Given this list of marker genes LHX5, LHX1, ASCL1, LMO4, TAL1, PAX7, GSX2, DRGX, GDF7, LHX3, GDNF, WNT1, PROX1, DRAXIN, PBX3, WNT3A, GSX1, DAAM2, MDGA1 (NCBI Gene Id 57164), HOXB8, UNCX, here is a description of the gene set: The process whose specific outcome is the progression of the dorsal region of the spinal cord over time, from its formation to the mature structure. The dorsal region of the mature spinal cord contains neurons that process and relay sensory input. studied in species Homo sapiens Human Gene Set: GOBP_DORSAL_SPINAL_CORD_DEVELOPMENT